The following is a description of a gene set: Genes down-regulated in NK cells versus CD8 T cells. Murine Cytomegalovirus (MCMV) infection leads to early activation of various immune cells, including B and T lymphocytes, before the actual initiation of antigen-specific adaptive immunity. This activation is partly driven by innate cytokines, including type I interferon (IFN), which are induced early after infection. The objective of this study was to address the role of type I IFN in shaping early/innate B and T cell responses to a primary acute viral infection. In order to decipher the specific impact of IFN-I on cell subsets, we performed a genome-wide expression analysis on WT splenic B and CD8 T lymphocytes isolated from C57BL/6 mixed bone marrow chimera mice. This study complements series GSE39555, which focused on early responses of NK cells and of the two subsets of conventional dendritic cells. species: Homo sapiens Human Gene Set: GSE45365_NK_CELL_VS_CD8_TCELL_DN, and this is the list of marker genes: BHLHE22, CDY1, TRIB1, USP9Y, FGD5, SH2D2A, GLUL, SPC24 (NCBI Gene Id 147841), SNCAIP, CLDN19 (NCBI Gene Id 30063), KIF26B, H3-3B, WWC3 (NCBI Gene Id 55841), XYLT2, COL22A1 (NCBI Gene Id 256626), VPS53, IGF2R, NUDT4, DEPTOR, TSC22D3, DPH3P1 (NCBI Gene Id 140827), CLASP1, IFNA8, GLT1D1, MYLK4, IL25, MLIP, H2BC21, NEURL1, CSRNP2, CDC123, TTTY13, MMS19, SST, SNX12, SH3RF3, LINC02871, FOSL1, ZNF613, HHAT, HJURP, PMS2P11, PRC1, CPM, HHIPL2, MXRA5 (NCBI Gene Id 91006), APEX1, POLR1HASP, JUN, ZNF185, DUSP1, OSBPL3, ADGRF4, TEX47, LINC00865, GCOM1, NLRC5, PTPRE, FAM66D, WDR64 (NCBI Gene Id 128025), FLYWCH2, UBOX5, ARHGEF6 (Rac/Cdc42 guanine nucleotide exchange factor 6), ST13, NRDC (NCBI Gene Id 4898), ZG16B, TOMM22, SERPINB6, KIF4A, SAMD3, AQP1, ZNF79, EYA1, SLC43A1, C8orf34-AS1, PPP5C, GBGT1, SNX1, VPS26B, RBM27, NKX3-2, CPVL, LGI2, FUT8, OR4D1, LINC00839, GABRA2, KCNMB4, USP18, MILR1, PARVB, MCMBP, SYNE3, EIF4B, ZNF436-AS1, DGCR2, PLEKHA5, SPATA8, BABAM1, TEX14, CYP4F30P, SEMA6D, MAEA, ZNF606, ACOXL, SLC22A23, MIA, MARK3, ABHD1, KIAA0586, MBL2, TARS2, GAS2L2, TUNAR, TEX101, IFT172, MOB1A, BCOR, GTF2H4, ZNF280C, ZNF425, RNF41, VAMP4, TPTE2P1, LINC01107, EXPH5, GPBP1L1, OTUD3, PRDM1, MUC3A, XPO7, PDZD2, FAM169A-AS1, C10orf55, PURPL, CFAP107, SLC25A20, TPTE2P6, DHX38, RMST (rhabdomyosarcoma 2 associated transcript), HOXA11-AS, METTL3, DPM3, OR7D2, GMPR2, VAT1L, IGFBP5, TXLNGY, SAMM50, DARS2, LINC02481, SNX9, IRS4, ATP2B2, SOX13, SMIM22, SLC24A1, C6orf58, ABI3BP, MELTF-AS1, ANKS4B, DDX19A-DT, NAT16, LRRC37A4P, TUSC2, WHAMMP2, PDS5B, ZKSCAN5 (NCBI Gene Id 23660), C6, ZNF836, RUVBL1, PIMREG, GNB3, PMS2P5, CENPC, CHRNB1, NCAN, C14orf28, PRPF3, CRKL, KRT5, GOSR1, NUP50-DT, POF1B, IGFLR1, FFAR4, ROBO2, ST6GAL2, ADGRF3, DNAJC4, ADAD1